The following is a description of a gene set: electronically inferred by orthology from the curated human pathway part of: Deadenylation-dependent mRNA decay Reactome Pathway: Deadenylation of mRNA species: Mus musculus This event has been computationally inferred from an event that has been demonstrated in another species.<p>The inference is based on the homology mapping from PANTHER. Briefly, reactions for which all involved PhysicalEntities (in input, output and catalyst) have a mapped orthologue/paralogue (for complexes at least 75% of components must have a mapping) are inferred to the other species., and this is the list of marker genes: Cnot10, Eif4a2, Pabpc1 (poly(A) binding protein, cytoplasmic 1), Tnks1bp1, Eif4a1, Cnot4 (CCR4-NOT transcription complex, subunit 4), Cnot7